The following is a description of a gene set: Mouse Gene Set: GOBP_NEGATIVE_REGULATION_OF_CENTRIOLE_REPLICATION studied in species Mus musculus Any process that stops, prevents, or reduces the frequency, rate or extent of centriole replication., and this is the list of marker genes: Kat2b, Rbm14, Trim37, Kat2a, Mdm1, Cdk5rap2